The following is a description of a gene set: Abnormal subpleural morphology Any structural anomaly located between the pleura and the chest wall. Human Gene Set: HP_ABNORMAL_SUBPLEURAL_MORPHOLOGY studied in species Homo sapiens, and this is the list of marker genes: SFTPA1, FAM13A, DSP, SLC34A2, SFTPA2, STN1 (STN1 subunit of CST complex, NCBI Gene Id 79991), RTEL1, MUC5B, DPP9, SFTPC, ABCA3, ATP11A, KMT2D, TERT, KDM6A, PARN (NCBI Gene Id 5073), TERC